The following is a description of a gene set: species: Homo sapiens Human Gene Set: GSE22886_DAY0_VS_DAY1_MONOCYTE_IN_CULTURE_UP Genes up-regulated in comparison of monocytes cultured for 0 days versus those cultured for 1 day. from publication Abbas AR, Baldwin D, Ma Y, Ouyang W, Gurney A, Martin F, Fong S, van Lookeren Campagne M, Godowski P, Williams PM, Chan AC, Clark HF (PMID 15789058) Immune cell-specific expression is one indication of the importance of a gene's role in the immune response. In order to identify such patterns, we set out to broadly profile gene expression in a variety of immune cells., and this is the list of marker genes: MTMR3, SLC35A1, C11orf21, ZNF467, TOR3A, RPLP2, HK3, FRAT1, CDA, ASGR2, ADD3, ZBTB18 (NCBI Gene Id 10472), F5, RPL29, ADA2, MEF2C, PLCL2, KLF11, ATP8A1, ITGA4, DPEP2, GBP2, CST3, CHPT1, ACAA1, CD33 (CD33 molecule), RERE, RPL27, PARP8, IGFBP7 (NCBI Gene Id 3490), SULT1A2, RAP1GAP2, ASGR1, RPS5, CD1D, LMO2, ALAD, LY75, KIAA0513, EPRS1, ENTPD1, ZFP36, RPL4, GAS7, MAN2B2, CCDC69, RPL21, SAMHD1, PLCB2, MXI1, ATR, PCYOX1L, F13A1, PIEZO1, BZW2, RBL2, STX10, CPPED1, RPS4X, PELI2, RIOX2, PYGL, TMEM131L, SATB1, FAM13A, CCR2, PLBD1, FGL2, NUP210, AGTPBP1, MTMR11, ZFP36L2, MBNL1, PHF21A, CD74, CD36, MYCBP2, LHPP, ADCY7, PADI2, RNASE2, FCGR1BP, FCN1, HMGN3, ZDHHC7, CSF3R, ARHGAP25, STK38, RPL13A, KLF2, ERP29, RASGRP2, BTK, CD37, CD101, SIDT2, SCPEP1, MSRB2, SMARCD3, CAT, FUCA1, RGS2, PSRC1, PDP1, NINJ2, MAPK14, VIPR1, ALDH2 (aldehyde dehydrogenase 2 family member), MARCHF1 (membrane associated ring-CH-type finger 1), SULT1A1, CD244, DOK2, OXA1L, LTA4H, NME3, NLRP1, SORL1, RNASET2, TGFBI (NCBI Gene Id 982), ICAM3, TNFSF10, TMT1A, INTS8, HAUS4, VCL, FRAT2, BIN2, CEBPD, PGM1, RPL26, NEK9, LY86, RPL30, RNF44, ZNF395, APBB1IP, FOS, CAST, PIK3CD, FAM8A1, UBA7, NPRL2, CRISPLD2, CPVL, TLR5, SECTM1, CFD, RPS2 (ribosomal protein S2), IRAG2, CX3CR1, RFX5, IMPA2, RPS29, STAT5B, ST6GAL1, TLR7, GSTK1, HMGB2, PECAM1, NRGN, RHOB (ras homolog family member B), IPCEF1, AIF1, MSRB1, SLC12A9, ICAM2, LMO4, KIAA0040, INPPL1, MNDA, TENT5A, UNC93B1, S100A4, RPS18, IFITM2, IKZF1, FES, REPIN1, HELZ, CNPY3, MGST2, FBL, COQ8A, SIGIRR, P2RY13, RPL35A, RPS8, NACC2, CLMN (calmin), SELL, MS4A6A, GIMAP4, FYB1, CBFA2T3, SUN1, CD302, LIMD2, MYD88, DUT, INPP5D (NCBI Gene Id 653796)